Given this list of marker genes Kidins220, Map2k1, Map2k2, Ngf, Mapk3, Crk, Frs2, here is a description of the gene set: This event has been computationally inferred from an event that has been demonstrated in another species.<p>The inference is based on the homology mapping from PANTHER. Briefly, reactions for which all involved PhysicalEntities (in input, output and catalyst) have a mapped orthologue/paralogue (for complexes at least 75% of components must have a mapping) are inferred to the other species. studied in species Mus musculus part of: Signalling to ERKs Reactome Pathway: Prolonged ERK activation events electronically inferred by orthology from the curated human pathway